Given this list of marker genes Rhoa, Tnf, Il5, Arhgef5, Csf2, Arpc2, Mapk8, Src, Lcp1, Mapk9, Msn, Fscn1, here is a description of the gene set: Any process that activates or increases the rate or extent of podosome assembly. studied in species Mus musculus Mouse Gene Set: GOBP_POSITIVE_REGULATION_OF_PODOSOME_ASSEMBLY